The following is a description of a gene set: species: Homo sapiens Human Gene Set: GAVISH_3CA_METAPROGRAM_CD4_T_CELLS_NAIVE_1 from publication Gavish A, Tyler M, Greenwald AC, Hoefflin R, Simkin D, Tschernichovsky R, Galili Darnell N, Somech E, Barbolin C, Antman T, Kovarsky D, Barrett T, Gonzalez Castro LN, Halder D, Chanoch-Myers R, Laffy J, Mints M, Wider A, Tal R, Spitzer A, Hara T, Raitses-Gurevich M, Stossel C, Golan T, Tirosh A, Suvà ML, Puram SV, Tirosh I (PMID 37258682) Genes upregulated in subsets of cells of a given type within various tumors In this study, an extensive analysis was conducted to define meta-programs (MPs) capturing intra-tumor heterogeneity across a spectrum of tumor types. The approach utilized non-negative matrix factorization (NMF) to analyze each cell type separately within individual tumor samples. This involved the analysis of malignant cells, macrophages, fibroblasts, endothelial cells, epithelial cells, T-cells, and B-cells. NMF was executed with varying parameter values (K=4, 5, 6, 7, 8, 9), thereby generating 39 programs for each cell type per sample. Each NMF program was summarized by the top genes based on NMF coefficients.\nRobust MPs were then delineated for each cell type using a set of stringent criteria, including recurrence within the same tumor, similarity to programs in other tumors, and non-redundancy within a tumor. Subsequently, these robust NMF programs were clustered (per cell type) based on Jaccard similarity, leading to the identification of MPs associated with each cell type.\nTo enhance the quality of the MPs, a refinement steps were undertaken, involving the removal of MPs suspected of reflecting low-quality data (with an overrepresentation of ribosomal proteins or mitochondrial-encoded genes), single-study inclusion, or similarity to miss-annotated cell types., and this is the list of marker genes: TOB1, ZFP36L2, KLRB1, GIMAP7, AREG, PLAC8, CXCR4, GPR171, FOS, CCL5, PPP2R5C, YPEL5, CD48, BTG2, ZNF331, DUSP1, GPR183, NOSIP, TXNIP, FOXP1, LEPROTL1, IL7R, FOSB, DNAJB1, SLC2A3, TMEM123, CCR7, TRAT1, LMNA, SNHG8, NR4A2, CD69, TCF7, ZFP36, SOCS3, CD55, RGCC, GZMA, DUSP2, KLF2, ALOX5AP, ANXA1, FAM177A1, SELL, GIMAP4, IER2, JUNB, PTGER4, PLAAT4, JUN